The following is a description of a gene set: Human Gene Set: GOBP_ANTIGEN_PROCESSING_AND_PRESENTATION_OF_EXOGENOUS_ANTIGEN species: Homo sapiens The process in which an antigen-presenting cell expresses antigen (peptide or lipid) of exogenous origin on its cell surface in association with an MHC protein complex., and this is the list of marker genes: CD1A, HLA-DQA1, FCGR2B, IKBKB, HLA-DQA2, CLEC4A, B2M, HLA-DRB3, HLA-DPA1, PIKFYVE, AP3D1, CTSD, HLA-DPB1, CD1D, TAP2 (transporter 2, ATP binding cassette subfamily B member), IFI30, CD74, UNC93B1, CTSV, MFSD6, HLA-DQB2, HLA-DRB5, HLA-DQB1 (major histocompatibility complex, class II, DQ beta 1), CD1C, AP3B1, CTSL, LNPEP, FCGR1A, HLA-F, HLA-A, MPEG1, HLA-DRB4, CTSS, CD1E, HLA-DRB1, MR1, CTSF, HLA-DOA, DNM2, HLA-DMA, CTSE, HLA-DMB, CD1B, PSME1, HLA-DOB, TRAF6, HLA-DRA, FCER1G, HLA-E, LGMN